Given this list of marker genes RLIM, ATP10B, GATA4, CTRC, CLDN12, CDC42EP1, ERBB3, NUPR1, LYPD1, CYP3A5, LGR4, GSTA2, TOB1, LGALS2, TMEM51, RPL39, POU2AF3, RPL18A, HPN, PIGR, CYB5A, ERO1A, LRP10, CCNG1, CASP7, CTTN, CD151, ITGA2 (NCBI Gene Id 3673), DNAJC3, RPL32, SAV1, RASEF, RPS24, REG3A, PARD3, PDLIM5, BHLHE40, CREG1, FUT4, ATRN, NFE2L2, TSPAN13, SPCS3, MAGT1, CPM, SNAP23, JUN, PRSS3, NOP53, KDELR3, KRT18, TUBA1C, NECTIN4, HSPB1, ETS2, RNASE1, PTP4A2, ADAM9, TMC5, HSD17B4, GPT2, B3GALNT2, RPS9, PPP1R3C, CLDN2, CCL28, ANKRD36B, RPS20, BCAT1, TMT1A, EIF4EBP1, TM9SF3, RPL13, GLRX, ALAD, HERPUD1 (homocysteine inducible ER protein with ubiquitin like domain 1), SMAD3, PRPS2, SRD5A3, CLPS, XBP1, AP4B1, MYO1C, SERPINB1, ABHD11, TMSB10, RPL14, SPINK1, NACA2, CLDN7, CFI, MYO5C, XPNPEP1, TM7SF2, VMP1, MXI1, PDP1, SLC12A7, JPT1, AMY2A, CCL20, SAT1, HDHD3, GUCD1 (NCBI Gene Id 83606), FTL, DUSP23, OLFM4, MLEC, SLC38A2, RACK1, PMAIP1, CEL, TRAF4, HLA-B, MTUS1, ACSL4, SORBS2, TMEM87B, GCLC, PRSS1, C1R, RPL7, SPTSSA, PSAT1, EEF1B2 (NCBI Gene Id 1933), ADD3, PLSCR1, HOMER2, ZC3H12A, TPT1, RPL10L, SLC25A37, NPM1, CTRB2, CELA3B, GPRC5A, PARP4, RPS7, AMY2B, CYP1A1, RPSA, RPS15A, PLA2G1B, TMC4, C5 (complement C5), PRDX4, CD44, CHMP4C (charged multivesicular body protein 4C), DUOX2, GALNT2, TMED9, TNFAIP1, ANGPTL4, NAMPT, TPM1, TSPAN15, HSPB8 (heat shock protein family B (small) member 8), VAPA, ANKRD36, ETV6, KCNQ1, RASGRP3, RRBP1, PPP2R5A, F3, RPL17, SERPINB6, TKT, KLF5, TNFRSF12A, LTB, RPSA2, EIF4EBP2, MLPH, TMEM97, PDGFA, DAG1, TGIF1, ALDOB, NET1, KIF1C, PIK3AP1, FNIP2, SMIM14, SHMT2, RPL4, TPD52L1, TPST2, PRR15L, OXA1L, PSMB8, ACAA1, CCND2, RPL31, FKBP1A, TOR1AIP2, CLDN10 (claudin 10), PNLIPRP1, CASP4, BACE2, DUSP4, PODXL, TRIB1, TCIRG1, RETSAT, EIF2S2, EML4, OSTC (NCBI Gene Id 58505), ZFP36L1, ARHGAP26, ITGAV, AKR1C3, SERPINF1, UBD, ASNS, CPA2, RPS19, CAPZA1, MARCKS, UBA52, GLUL, OSMR, RBSN, ELF3, TNFAIP8, FAM107B, MECOM, ENC1, DUSP16, AKR7A3, SHROOM3, RPL35, ZNF114, UGT2B15, TMEM123, HEBP1, NCOA7, OCLN, PRSS3P2 (NCBI Gene Id 154754), GULP1, MOB3B, FLRT2, RPS4Y1, MYL12A, RPS8, PGM3, PACSIN2, MYL12B, MAN2A1, ABCC3, SERINC2, ANPEP, RETREG1, RAB9A, KLK1, CTRL, EIF2S3 (NCBI Gene Id 8422), C3, RPL26, SERP1, FTH1, LMO7, SLC66A3, NRARP (NOTCH regulated ankyrin repeat protein), ESRP1, RER1, MGAT4B, RPL10A, CLIC6, CEBPD, PTMAP11, LIMA1, IDH2, TCIM, RPL7A, RPL13A (NCBI Gene Id 94020), EEF1A1, RPL24 (ribosomal protein L24), CREB3L1, PPIA (peptidylprolyl isomerase A), RND1, LRG1, ATF3, EPB41L4B, RPL36AL, KITLG, MCCC1, AHCY, RPL36A-HNRNPH2, RPL34, TMEM98, USP53, SLC7A11 (solute carrier family 7 member 11), ENAH, GAREM1, RPS2, ALDH3A2, SOD2, PABPC4, GCNT3, CPB1, MTMR12, AQP8, HIF1A, CMPK1, GMNN, PYCR1, TST, RNF213, FNDC4, EDEM3, GOLM1, RPS27, TACSTD2, CASP6, ACTN4, CPA4, BAZ1A, CXCL3, PSMB10, MSN, C4orf19, MT1G, DBNDD1, HLA-C, SGK1, EEF1G, TM4SF1, AADAC, SLC39A8, GDF15, SOX4, SSR3, EIF3F, SLC30A2 (solute carrier family 30 member 2), ATF4, RPS16, TXN (NCBI Gene Id 7295), CXADR, TMSB4X (thymosin beta 4 X-linked), TNFAIP3, SNHG5, RAB27B, S100A11 (S100 calcium binding protein A11), CYFIP1, FKBP9P1, RPS6KA2, KLF3, PTPRK, FGA, RPL35A, FGL1, CLDN4, RPN2, REG3G, FBXO25, ITPRID2, KRT8, SLC39A14, SUCLG2, PTGFRN, RPL38 (ribosomal protein L38), RPL19, MCFD2, B2M, NHSL3, IGFBP2, RPL37A, RNF181, EHD4, NFKBIA, ARHGAP18, EGFR, VTN, MACC1, SLC22A23, TRAM1, LCN2, OAF, TP53INP1, PHLDA1, SRI, TUBB2A, MAP3K20, CBS, LIMK2 (NCBI Gene Id 3985), IL22RA1, PIM3, RPS4X, CD24, REG1B, SEL1L3, ANXA4, RPS25, DDAH1, HDGF, MARCKSL1, NTN4, RPL23A, JUP, IGBP1, BAIAP2L1, CTSD, MYO5B, RPL27, RPS11, TP53I11, IL32, NFKBIZ, FAM13A (family with sequence similarity 13 member A), CXCL16, KRAS, GBP2, SETD7, RPL37, TRIM47, TCN1, ZFAND5, PGM2L1, ZNF117, FOXC1, GALNT7, TUBB3, RPLP1, NIBAN1, NEAT1, FAM161A, ANO6, RPS28, TMEM165, HSD17B11, POLDIP2, LGALS3 (galectin 3), FGD6, PCBP2, CCNC, PNRC1, TNFSF10, C1RL, EIF3L, ANXA11, POLD4, MYC, TES, PDZK1IP1, SOCS3, ARSD, CNN2, PABPC3, RPS21, IFITM3, RPL36, GSTA1, STEAP4, TALDO1, GPR160, RDX, LASP1, B3GNT5, SDC4, RBM47, PTMA, CCL8, CXCL1, CLDN1, EEF2 (NCBI Gene Id 408221), SLC12A2, RPL29, CES2, YBX3, GRB10, B4GALT1, FTH1P3, PBLD (phenazine biosynthesis like protein domain containing), BMF, YAP1, ADM2, TFPI, RPL23, IDH1, MTHFD2, TSPAN6, SORD, DAB2IP, ARPC1A, RPL27A, EBP, RBPJ, PTER, AMOTL2, ERP27, RPS3A, PRDX6, IMPDH2, PNLIP, PTPRF, HLA-DRB1, NACA, CDR2L, RPL13AP5, LDHB, AKR1B10 (NCBI Gene Id 9405), REG1A (regenerating family member 1 alpha), RPL41, TMBIM1, EIF4E2, RPL36A, ACTG1, SLC44A4, ZNF704, ARRDC3, VIM, RPS5, CXCL12, PNLIPRP2, GPRC5B, RPS13, PRDX1, CD74, TMED2, FAM3B, PDCD4, PLIN5, TBC1D1, MUC20, NEXN, HEYL, MBNL2, UBE2H, RPS27L, CEMIP2 (cell migration inducing hyaluronidase 2, NCBI Gene Id 23670), TCEA3, GALNT3, CHAC1, SEL1L, GJB1, LSR, AOX1, SKIL, C2CD2, H6PD, NDRG1, CDV3, CCL2, MAL2, ACO1, REST, ZNF217, RPL11, PARVA, MET, RSU1, HLA-DMA, RPS29, NR5A2, RPL30, MKNK2, SQSTM1, CFB, FGG, REPS2, CAV2, NEDD4L, CAMK1D, BTF3, MUC1, FA2H, CHP1, CDH1, PDLIM1, RPL10, GATM, CTRB1, RASSF6, KRT7, RAB11FIP1, B3GNT2, ADI1, MLXIP, POLR1D, CD47, RPLP0, CCPG1, INSR, RAB3D, FZD5 (frizzled class receptor 5), CXCL8, RBPMS, SYTL2, TNFRSF10B, CNN3, SOX9, CELA2B, PPIC, RHOC (ras homolog family member C), UNC5CL, PTP4A1, PARD6B, CD2AP, CYP17A1, HLA-F, EIF3E, SERPINA3, WIPI1, HTATIP2, CBR1, SPATA13 (NCBI Gene Id 221178), SLC35E1, BIRC3, SCN9A, SPSB1 (NCBI Gene Id 80176), RPL12, UGDH, HES1, IFNGR1, RPLP0P2, LGALS9, MCL1, BTG1, CPA1, FRMD8, ALB, RDH10, TXNRD1, TMEM125, IL18, RPLP2, NFIB, P4HB, BNIP5, LAD1, FBP1, PLS3, ATP8B1, LRRC59 (NCBI Gene Id 55379), GATA6, CLMN, RPS6, TRIB2, EBPL, CXCL2, PGM1, CAPN2, IMPA2, TUBB4B, SLC25A5, RPS27A, MYH9, FKBP11, RPS23, ITGA6, LDHA, LYN, RPS3, PTF1A, SYNGR2, CREB5, RPL22L1, SLC16A7, C15orf48, RPL23P8, MAP3K5, GPX2, SLC35D2, SERPINI2, PPIF, SH3BP4, SPTBN1, MXRA5, RPL13AP20, ABRACL, PTGR1, RBM3, DHRS3, EIF3D, CXCL17, AKR1C2, LYZ, FDX1, SP100, TAGLN2, NHSL2, SH2D4A, SLFN5, KRTCAP3, EPHX1, RPL9, CELA3A, STAT6, CGNL1, ADH1C, TMEM41A, TJP2, TAPBP, STK24, PHGDH, ASS1, PLTP, RPS12, YWHAZ, FAM162A, HLA-DRA, REG1CP, STK17A, SLC38A1, VAMP8, EDN1, MGST1, BCL3, B3GNT7, TMPRSS2 (NCBI Gene Id 7113), NR0B2, HHLA2, KLF6 (KLF transcription factor 6), IER2, BLVRB, AKR1C1, ADAMTS1, ACOX1, CELA2A, PABPC1, TC2N, CA12, RNF19A, IQGAP2, GP2, ALDH2, EEF1D, GSTP1, LAMB3, F11R, NIBAN2, here is a description of the gene set: from publication Muraro MJ, Dharmadhikari G, Grün D, Groen N, Dielen T, Jansen E, van Gurp L, Engelse MA, Carlotti F, de Koning EJ, van Oudenaarden A (PMID 27693023) studied in species Homo sapiens Human Gene Set: MURARO_PANCREAS_ACINAR_CELL